Given this list of marker genes MAOA, ALDH2, here is a description of the gene set: part of: Serotonin clearance from the synaptic cleft species: Homo sapiens Serotonin is first metabolized to 5-hydroxyindole acetaldehyde by monoamine oxidase. 5-hydroxyindole acetaldehyde is then catalyzed by aldehyde dehydrogenase to form 5-hydroxyindole acetic acid. Reactome Pathway: Metabolism of serotonin